The following is a description of a gene set: species: Homo sapiens Human Gene Set: GOMF_DOUBLE_STRANDED_TELOMERIC_DNA_BINDING Binding to double-stranded telomere-associated DNA., and this is the list of marker genes: RAD50, HMBOX1, TERF1, APEX1, PURA, XRCC5, XRCC6, TERF2, ZBTB48